Given this list of marker genes STAT5B, MBD5, PTPN1, SHOC2, GHRL, CSH1, CSH2, SOCS2, GH2, JAK2, IGF1, CSF2RA, CSHL1, LEPROT, JAK3, LEPROTL1 (NCBI Gene Id 23484), PXN, PTK2, JAK1, HNF4A, PIK3R1, LYN, GH1, STAT5A, STAT6, STAT3, GHR, GDF15, TYK2 (NCBI Gene Id 7297), here is a description of the gene set: Any process that results in a change in state or activity of a cell (in terms of movement, secretion, enzyme production, gene expression, etc.) as a result of a growth hormone stimulus. Growth hormone is a peptide hormone that binds to the growth hormone receptor and stimulates growth. Human Gene Set: GOBP_CELLULAR_RESPONSE_TO_GROWTH_HORMONE_STIMULUS studied in species Homo sapiens